The following is a description of a gene set: Any process that modulates the frequency, rate, or extent of toll-like receptor 3 signaling pathway. Human Gene Set: GOBP_REGULATION_OF_TOLL_LIKE_RECEPTOR_3_SIGNALING_PATHWAY studied in species Homo sapiens, and this is the list of marker genes: PTPN22, TNFAIP3, FLOT2, F2RL1, HCFC2, UBQLN1, FLOT1, TIRAP, CAV1, WDFY1, PELI1, TRIM3, SRC